Given this list of marker genes NCF1, CYBB, CYBA, ITGAV, NCF4, ITGB5, CD36, NCF2, here is a description of the gene set: Dendritic cells (DCs) take up and process exogenous particulate or cell-associated antigens such as microbes or tumor cells for MHC-I cross-presentation. Particulate antigens have been reported to be more efficiently cross-presented than soluble antigens by DCs. Particulate antigens are internalized by phagosomes. There are two established models that explain the mechanism by which exogenous particulate antigens are presented through MHC I; the cytosolic pathway where internalized antigens are somehow translocated from phagosomes into cytosol for proteasomal degradation and the vacuolar pathway. part of: Antigen processing-Cross presentation Reactome Pathway: Cross-presentation of particulate exogenous antigens (phagosomes) studied in species Homo sapiens